Given this list of marker genes CCDC40, ZIC3, DNAAF1, CCDC39, NPHP3, here is a description of the gene set: Human Gene Set: GOBP_DETERMINATION_OF_PANCREATIC_LEFT_RIGHT_ASYMMETRY Determination of the asymmetric location of the pancreas with respect to the left and right halves of the organism. studied in species Homo sapiens